Given this list of marker genes C12orf57, KBTBD13, SCN4A, SLC8A3, CASQ1, DMPK, ATP2A1, KCNJ2, GSTO1, ACTN3, DMD, REM1, PRKD1, FKBP1A, CAV3, MYH7, ADGRD1, GSTM2, STRIT1, here is a description of the gene set: Human Gene Set: GOBP_REGULATION_OF_SKELETAL_MUSCLE_CONTRACTION Any process that modulates the frequency, rate or extent of skeletal muscle contraction. species: Homo sapiens